Given this list of marker genes Mfng, Ugt1a7c, Large1, Cercam, Ugt1a5, Galntl6, Mgat4c, Ugt1a10, Ugt1a6b, Abo, Csgalnact2, A4galt, Mgat4f, Gbgt1, Mgat4e, Ugt2a2, Gbe1, B3gntl1, Sec1, Galnt12, Galnt16, Has2, Epm2a, B3galt5, Gys1, Ugt2a1, Galnt13, Ugt1a8, Mgat2, 4930568D16Rik, Extl1, Poglut2, Gcnt3, Tmtc1, B3gnt9, Rfng, Galnt3 (polypeptide N-acetylgalactosaminyltransferase 3), Alg11, Chpf2, Ugt1a2, Pigv, Alg3, Gba2, Pygb, Has3, Gcnt1 (NCBI Gene Id 71444), B4galt1, Ugcg, Stt3b, Ugt1a9, Fut8, Pomt2, Hexb (hexosaminidase B), Pygm, Mgat4d, Ugt2b35, Ext2, Fut4, Alg13, Hyal1, Uggt1, B3gat3, Gyg1, Mgat4b, Ugt2b34, Colgalt2, B3galnt2 (NCBI Gene Id 97884), Pygl, Extl2, Gba1, Tymp, B3galt6, Dpy19l3, B3gnt5, B3gnt2, Pigp, Pomgnt2, Dpm2, Tmtc2, Galnt4, B3galt1, Galnt2, Fut10, Galnt9, Stt3a, Alg1, B3glct, B3galnt1, Ugt2b5 (NCBI Gene Id 22238), Mgat5b, Chsy3, Ugt2a3, Chpf, B3gnt6, Alg9, Alg2, Dpy19l2, Wdfy3, Fut9, Gys2, Galnt11, Poglut3, B4galnt3, B3gnt8, Tmem260, C1galt1, Plod3, B4galt7, Galnt18, Ogt, Uggt2, Galnt10, Dpm1, Ugt2b38 (UDP glucuronosyltransferase 2 family, polypeptide B38), B3gat2, Alg6, Galnt15, Colgalt1, Galnt17, Lalba, Chsy1, Pomt1, Has1, Glt6d1, Poglut1, Pomgnt1, Tmtc4, Alg12 (NCBI Gene Id 223774), Dpy19l1, Lfng (LFNG O-fucosylpeptide 3-beta-N-acetylglucosaminyltransferase), Ggta1, Galnt6, B4galt2, Gcnt7, Csgalnact1, Ugt1a1 (NCBI Gene Id 394436), B3galt2, Galnt5, Alg8, Pigz, Ugt8a, A4gnt, Agl, Alg5, A3galt2, Ugt2b37, Gcnt4, Pigq, B3gat1 (NCBI Gene Id 76898), B4galt5, B4galnt1, Galnt7, Pigyl, Ugt2b36, Gcnt2, B3galt4, Pofut1, Pigm, B3gnt7, Fut7, B4galnt4, Large2, Mgat5, C1galt1c1, Ugt3a2, Gtdc1, Ext1, Piga, B3gnt3, Galnt14, B4galt3, Fut2, Tmtc3, Alg10b, Mgat3, B4galnt2, B4galt6, Mgat4a, Hexa, Dpy19l4, B4galt4, Mgat1, Pofut2, Galnt1, Extl3, Pigb, Ugt3a1, Fut11, Ugt2b1, B3gnt4, Ugt1a6a, Eogt, B4gat1, Fut1, here is a description of the gene set: Mouse Gene Set: GOMF_HEXOSYLTRANSFERASE_ACTIVITY species: Mus musculus Catalysis of the transfer of a hexosyl group from one compound (donor) to another (acceptor).